Given this list of marker genes Smpd4, Rbbp4, Zfp428, Inka1, Cisd1, Prdm4, Eftud2, Ino80e, Ptgr1, Cplx2, Elovl6, Mms22l, Cep89, Shmt1, Gclc, Tysnd1, Traf4, Rai1, Dnaaf2, Tipin, Lsm6, Rnf2, Mthfd1, Mcm7, Akt3, Bcat1, Chchd10, Mutyh, Erh (ERH mRNA splicing and mitosis factor), Pclaf, Dab2ip, Rfc3, Uhrf1, Myb, Akap12, Eif4ebp2, Mis18bp1, Dyrk2, Trim28, Smarca4, Phb2, Elof1, Cdk9, Ssrp1, Hmga1, Wdhd1, Gemin5, Srsf2, Smarcb1, Ahcyl, Med9, Smt3h2-ps (SMT3 suppressor of mif two 3 homolog 2, pseudogene (S. cerevisiae)), Lig1, Snrpb, Fkbp3, Mdm1, Dck, Cox5a (NCBI Gene Id 12858), Ddx47 (NCBI Gene Id 97288), U2af2, Plekha2, Prim2, 4933439C10Rik, Sapcd2, Otub2, Igf2bp3, Moap1, Tcf3, Zbed3, Poc1b, Faap24, Pidd1, 1810059H22Rik, Jmjd4, Smarcd2 (SWI/SNF related, matrix associated, actin dependent regulator of chromatin, subfamily d, member 2), Ilf3, Sf3b6, Blmh, Strbp, Pde2a, Agk, Traf5, Kif18b, Synj2bp, H1f3, Ranbp1, Cactin, Sephs1, Smc1a, Cdca4, Cenpo, Llgl1, Cenps, Cbll1, Cbx2, Ube3d, Cdk1, 2610318N02Rik, Topbp1, Rbmxl1, Ebf1, Cbx1, Hprt1, Cenpn, Fancm, Gins2, Lgals9 (lectin, galactose binding, soluble 9), Fam20b, Bub1b, Spag5, Suz12, Inip, Trib2, Mrps18a, here is a description of the gene set: Genes correlated with the early tumor onset in the Emu-myc transgenic mouse lymphoma model. Mouse Gene Set: MORI_EMU_MYC_LYMPHOMA_BY_ONSET_TIME_UP The Emu-myc transgenic mouse has provided a valuable model for the study of B-cell lymphoma. Making use of gene expression analysis and, in particular, expression signatures of cell signaling pathway activation, we now show that several forms of B lymphoma can be identified in the Emu-myc mice associated with time of tumor onset. Furthermore, one form of Emu-myc tumor with pre-B character is shown to resemble human Burkitt lymphoma, whereas others exhibit more differentiated B-cell characteristics and show similarity with human diffuse large B-cell lymphoma in the pattern of gene expression, as well as oncogenic pathway activation. Importantly, we show that signatures of oncogenic pathway activity provide further dissection of the spectrum of diffuse large B-cell lymphoma, identifying a subset of patients who have very poor prognosis and could benefit from more aggressive or novel therapeutic strategies. Taken together, these studies provide insight into the complexity of the oncogenic process and a novel strategy for dissecting the heterogeneity of B lymphoma. species: Mus musculus from publication Mori S, Rempel RE, Chang JT, Yao G, Lagoo AS, Potti A, Bild A, Nevins JR (PMID 18922927)